The following is a description of a gene set: Human Gene Set: MOREAUX_MULTIPLE_MYELOMA_BY_TACI_DN Down-regulated genes distinguishing in multiple myeloma (MM) samples with lower expression of TACI. from publication Moreaux J, Cremer FW, Reme T, Raab M, Mahtouk K, Kaukel P, Pantesco V, De Vos J, Jourdan E, Jauch A, Legouffe E, Moos M, Fiol G, Goldschmidt H, Rossi JF, Hose D, Klein B (PMID 15827134) B-cell activating factor (BAFF) and a proliferation-inducing ligand (APRIL) have been shown to promote multiple myeloma (MM) cell growth. We show that the main site of production for BAFF and APRIL is the bone marrow (BM) environment, and that production is mainly by monocytes and neutrophils. In addition, osteoclasts produce very high levels of APRIL, unlike BM stromal cells. Myeloma cells (MMCs) express TACI (transmembrane activator and calcium modulator and cyclophilin ligand interactor), the receptor of BAFF/APRIL, at varying levels. TACI expression is a good indicator of a BAFF-binding receptor. Expression data of purified MMCs from 65 newly diagnosed patients have been generated using Affymetrix microarrays and were analyzed by supervised clustering of groups with higher (TACI(hi)) versus lower (TACI(lo)) TACI expression levels. Patients in the TACI(lo) group had clinical parameters associated with bad prognosis. A set of genes was differentially expressed between TACI(hi) and TACI(lo) MMCs. This set makes it possible to efficiently classify TACI(hi) and TACI(lo) MMCs in an independent cohort of 40 patients. TACI(hi) MMCs displayed a mature plasma cell gene signature, indicating dependence on the BM environment. In contrast, the TACI(lo) group had a gene signature of plasmablasts, suggesting an attenuated dependence on the BM environment. Taken together, our findings suggest using gene expression profiling to identify the group of patients who might benefit most from treatment with BAFF/APRIL inhibitors. studied in species Homo sapiens, and this is the list of marker genes: ACTL6A, GUSBP14, GPR89B, ZBTB20, TIMM29, CYP2R1, CEP295, EBNA1BP2, SLC25A36, FIBP, EZH2, ANKRD49, DHX29, C11orf54, G3BP1, SF3B2, ZCCHC10, SKIC8, PSMC4, MRPL43, SSBP1, ORC5, CDIN1, BARD1, GCSH, COMMD4 (COMM domain containing 4), NDUFA13, PEX1, SNX19, ZNF567, UPF3A, MRPS12, TENT2, RFX7, TERF1, PSMA3, DDX31, SLC38A1 (solute carrier family 38 member 1), TMEM135, NOL8, PAK1IP1, UTP4, YJU2, MYLIP, RACGAP1, PPP2R5C, EIF3M, BTBD1, FAM98B, RUVBL2, ELAC1, TYMS, ACTR6, TEFM, ZNF131, RSF1, TDP2, TSHZ1, NMT1, MINDY3, NASP, PPP1R12A, NUDCD2, MCM2, FANCF, SLC33A1, TMA16 (translation machinery associated 16 homolog), CDC23, TMEM267, LRRC40, TIMM50, NUDT5, C1QBP, TMEM165, CCT2, GLT8D1, CCT5, SMARCA4, CEP57, KLF13, PSMD8, RAN, PAAF1, CHMP4A, NCLN, IK, TATDN1, AIMP2, MRPL50, ZNF367, MALSU1, KEAP1, DARS1, ZNG1A, ZNF277, EDRF1, MET, NCAPD3, STAM2, RIOX2, SPAST, OTUD6B, PDCD6, LEMD3, PTPMT1, CEP152 (NCBI Gene Id 23701), DBF4, LSM5, FEM1B, GEMIN5, AASDHPPT, DNAJB14, TLE4, TMEM126A, EFTUD2, DENND4A, HIKESHI, CDK1, EIF3G, CHEK1, PRKDC, MRPL19, BUB3, ABHD3, LAP3, NADSYN1, IP6K2, THYN1, PFDN4, AVL9, IFT74, PMS2P3, MBD4, IFT57, SLC16A1, TAF2, MCM3AP, LSM4, MATR3, CHCHD1, C1orf131, AFG2B, PPIP5K2, IREB2, RNF7, ANAPC10, HAUS1, NNT, KRIT1 (KRIT1 ankyrin repeat containing), EOGT (NCBI Gene Id 79580), ASF1A, MINPP1, RPL26L1, ACD, SEM1, DKC1, IARS1, SGO2, PAIP1, SNRPD1, PAPOLA, TBCB, EMC4, RNF111, TRIB1, MPHOSPH9, DDX1, ATP5MG, ILF3, ERCC1, CMC1, NAA50, NOMO3, DDX18, DUXAP8